Given this list of marker genes Far2, Awat2, Awat1, here is a description of the gene set: electronically inferred by orthology from the curated human pathway Reactome Pathway: Wax biosynthesis species: Mus musculus part of: Wax and plasmalogen biosynthesis This event has been computationally inferred from an event that has been demonstrated in another species.<p>The inference is based on the homology mapping from PANTHER. Briefly, reactions for which all involved PhysicalEntities (in input, output and catalyst) have a mapped orthologue/paralogue (for complexes at least 75% of components must have a mapping) are inferred to the other species.